The following is a description of a gene set: species: Homo sapiens Human Gene Set: HP_GRANULOMATOSIS Granulomatosis A granulomatous inflammation leading to multiple granuloma formation, which is a specific type of inflammation. A granuloma is a focal compact collection of inflammatory cells, mononuclear cells predominating, usually as a result of the persistence of a non-degradable product and of active cell mediated hypersensitivity., and this is the list of marker genes: NCF2, CYBA, NCF1, HLA-DPB1, HLA-DPA1, CTLA4, PTPN22, PRTN3, CYBB, ASAH1